Given this list of marker genes PLK3, SSPN, GPCPD1, ALOX5AP, NRBF2, GJC3, CARD9, RPL15, CYP26A1, RBM10, GBP6, FOXO1, BAG3, SCN1B, MANF, BLK, ALG3, NNT, GLIS3, IGFBP1, EN1, PDE3A, CRISP3, ERRFI1, OPRK1, SLC32A1, GKN2, KLHL30 (kelch like family member 30), RAMP3, TXNDC17, TOMM20, GNA13, SERTAD2, LHFPL5, ENG, RASGEF1C, NEDD4L, RASSF7, SPEG, RHOH, PEDS1, IL31, UOX, ADGRL4, SLC34A3 (solute carrier family 34 member 3), SAR1A, PCBP1, VIP, WNT10A, UBE2D3, MCFD2 (NCBI Gene Id 90411), SLC5A3 (solute carrier family 5 member 3), RAVER2, MAGEA6, CTXN1, PFKP, TRMT112, SERINC5, KCNAB1, H2BC8, HTR5A, SLC17A2, VWA5A, TMEM104, TEX261, CD44, PRSS2, IQSEC1, GRM3, RNF4, ECH1, ZC2HC1B, TAAR3P, FBXL21P, TMEM210, OTUB2, SS18, PHYHD1, TXNIP, PKD2L2 (polycystin 2 like 2, transient receptor potential cation channel), RNF212, NISCH, HSPA2, RHBDL1, ANKAR, MIR186, MED21, CORO6, ADAMTS6, SLC18A3, FKBP7, MIR499A (NCBI Gene Id 574501), RMND5A, KMT5C, CBL, THAP1, ASNS, DNMBP, CDV3, TMEM182, ADAMTS15, UBL4B, NR0B2, EDC4, ADAD1 (NCBI Gene Id 132612), JAK2, NAA20, RAMP1, ANGPTL3, CRHR2 (NCBI Gene Id 1395), TRAF3IP2, ADGRF1, GLUL, C19orf38, CCL7, SSBP2, KIT, MTM1, SLC66A2, PTPN7, DCTPP1, here is a description of the gene set: Genes down-regulated in wildtype bone marrow-derived macrophages treated with rosiglitazone: control versus IL4. Conditional macrophage-specific PPARg knockout mice were generated on C57Bl/6 background by breeding PPARg fl/- (one allele is floxed, the other is null) and lysozyme Cre transgenic mice. PPARg and IL-4 signaling was analyzed on bone marrow-derived macrophages. Bone marrow of 3 mice per group was isolated and differentiated to macrophages with M-CSF (20 ng/ml). 20 ng/ml IL-4 was used to induce alternative macrophage activation and 1 uM Rosiglitazone (RSG) was used to activate PPARg. From each mouse 4 samples were generated: 1. M-CSF, 2. M-CSF+RSG, 3. IL-4 and 4. IL-4+RSG. All compounds were added throughout the whole differentiation process, and fresh media was added every other day. Control cells were treated with vehicle (DMSO:ethanol). After 10 days, RNA was isolated and gene expression profiles were analyzed using Mouse Genome 430 2.0 microarrays from Affymetrix. from publication Szanto A, Balint BL, Nagy ZS, Barta E, Dezso B, Pap A, Szeles L, Poliska S, Oros M, Evans RM, Barak Y, Schwabe J, Nagy L (PMID 21093321) Human Gene Set: GSE25123_ROSIGLITAZONE_VS_IL4_AND_ROSIGLITAZONE_STIM_MACROPHAGE_DAY10_DN studied in species Homo sapiens